The following is a description of a gene set: studied in species Homo sapiens Genes predicted to be targets of miRBase v22 microRNA hsa-miR-6867-5p in miRDB v6.0 with MirTarget v4 prediction scores > 80 (high confidence targets). from publication Chen Y, Wang X (PMID 31504780) Human Gene Set: MIR6867_5P, and this is the list of marker genes: ZSWIM6, KLHL13, NLN, HYKK, PLAG1, CACNA2D2, LDB3, SVBP, CHRDL1, MATCAP1, CSF2RB, ARID3B, BRINP1, RAB3C, EHD2, TNKS, SLC13A5, OPCML, MYLK3, UNC5C, PRKD3, STXBP5L, KCNB1, PPP1R16B, AP1G1, EPS15L1, NLGN4Y, GFPT1, DLG1, BEAN1, TMEM151B, CACNA1I, SSX3, PCDH11Y, FCGR1BP, P2RY8, LRATD1 (LRAT domain containing 1), DCX, RPS3A, TTI1, CHST3, CRHBP (corticotropin releasing hormone binding protein), MAN1C1, PRDM8, PLAA, SIN3A, PLVAP, ZEB1, GPBP1L1, GIMAP1, KCNIP3, CLEC12B, RHOBTB1, ATP8B2, KCNQ3, BDH1, SEMA6A, PARD3B, LMX1B, LEPR, BRWD3, JAKMIP2, PDE10A, ENPP5, RNF113B, MESP2, VAPB, SMAD4, NRXN3, GNG7, ABR, ITIH5, NACC1, CREBBP, IGF1R, PODN, FUT9, TRPV3, ASXL2, ZDHHC20, SLC7A8, MTCL2, TULP3, UBQLN2, PLP1, PHF1, TTC9, EML1, FAM228A, PCDH10, ATP11A, TLK2, TTC1, PTAR1, PKNOX2, SH2D2A, TMEM196, CCDC83, ELAVL4, SIGMAR1, DOP1A, MAP4K5, FAM43A, NAPB, SLC35A3, DELE1, ZFX (NCBI Gene Id 7543), SERTAD2, TFAP2B, ATP6V1C2, ZNF382, SLC6A14, UNK, SDK2, ENSG00000255537, EHD3, NAPEPLD, JMJD8, RPL23A, LDHAL6A, CBX1, PREX2, SNAP25, NFIC, CD38, TANGO2, ANAPC7, RBMXL1 (RBMX like 1), NLK, FIBIN, PPP1R3A, TPTE, IL2RA, ABHD18, ASB7, MALT1, SPATA6, FRMD3, HSPG2, DOK6, PARM1, HLA-DOA, DDHD1, PLEKHA6 (NCBI Gene Id 22874), FNDC7, NDFIP2, EFHC2, FGF2, LCE1E, TAOK1, KDM3B, ASTN1, CLIC6, RALB, ADAM12, KCNQ5, FZD5, TNPO3, KIAA1549L, EFNB1, MDGA1, CREB3L2, CTSE, REEP5, RIGI, ST18, CD40LG, HSPB7, DLG4, LRTM2, KCNK10, GLS, APBA1, PAPSS2, NEXMIF, SSX4B, CD247, GPR173, ERP27, GARRE1, TMEM106A, PRKN, SLC16A14, ADAT2 (adenosine deaminase tRNA specific 2), LAIR1, ELFN1, SH3TC2, NCDN, MECP2, PFN1, DLGAP4, CSRNP3, SLC2A12, CCDC97, TBX15, KLF7, ARHGAP35, SBK1, DDX52, ZNF516, RRP7A, MAF, ZNF704, SATB1, TRIM2, UBN2, NTRK2, ALG1, ZNF148, KRIT1, FOXI2, IGLON5, STBD1, OLFML1, CDON, RBPJL, CSNK1G1, CARNS1, RNF220, MGRN1, CALD1, KPNB1, ZFP90, CHODL, PAX5, TBX4, ZFHX2 (zinc finger homeobox 2, NCBI Gene Id 85446), SPCS2, PIGH, ZNF488, INSIG2, ANTXR2, CDH11, TEAD1, ADCY2 (adenylate cyclase 2), GLP1R, EP300, TLX1, SPOCK2, SLCO4C1, STS, PAX6, NCAPH2, MYO5A, WWC1, BRINP2, SORCS3, RFTN2, SVIP, SPTLC3, GTF2H1, GNAT1, SLC22A23, RSPO1, ZC3H12D, SV2B, SPPL3, SNAP29, CSRNP2, AMER3, ADAM23, ACOD1, GRIN3B, SSX5, MACROH2A2, SSPN, WDR33, RSPRY1, IFNLR1, ARHGEF33, EIF2A, NCAM1, SHISA7, UNC5A, SOX12, ZNF563, LCP1, SLCO3A1, NEK11, CISD3 (NCBI Gene Id 284106), GRIN2A, TRIM42, CDKN2B, CLVS2, GALNT13, KLHL9, ETV6, KIF5A, MORC2, SSX2, RPH3A, NFASC, TENM2, ARHGAP26, KATNAL1, VAMP4, ZNF134, ZFY, IARS1, SGCZ, ATXN3, MGAT4A, IFT80, EBF3, TMEM150C, AMOTL1, NGFR (nerve growth factor receptor), CPPED1, F7, ZNF436, LRRC55, SNAI2, RALGAPB, STRBP, SBSPON, ELOVL6, CALCOCO1, POU4F2, MUC4, GALR2 (NCBI Gene Id 8811), ZKSCAN8, PURA, ADAMTSL1, SH3BGRL2, ATP2B2, CPED1, RET, GFRA2, ZEB2, TEAD3, PIK3C2A, GALNT3, CCDC93, KCNQ2 (potassium voltage-gated channel subfamily Q member 2), SYT3, BCOR, PPARA, KAAG1, SLC1A4, SEMA6D (semaphorin 6D), HAS2, NLGN3, SSX7, MBNL3, CD22, FAM117B, DMD, MYT1L, ANO5, PRKCI, WIZ, PAX4, PIK3R5, VGLL3, PLCB1, ADAMTS19, GDAP1, RSPO4, SOX6, SCN2A, STARD8, GFRA1, CSMD2, GABRB2, STX1B, RNLS, E2F8, TNS1, DGKH, PBRM1, SAMD4A, ZFHX3, AKT3, PALM2AKAP2, SYNPO2, NMBR, BEND6, CREM, LUM, PIAS2, ZNF37A, FAM177A1, VPS13C, ROCK2, NRXN1, SLC31A1, ZMYND8, MFSD6, SEPHS2, SETD7, ADAMTS5, ZNF329, GREB1, TREML2, MXD1, ERO1B, TIAM1, USP37, LHX6, RGS4, CAMK1D, ST8SIA1, DCAKD, CELF5 (NCBI Gene Id 60680), BDNF, KLHL15, CABP4, ZHX3, CLIP2, BMP4, ELFN2, VSTM2A, SMARCA2, FCRL6, ARHGAP42, TNRC6B, COPG2, GABBR2, ASB11, PATE2, ZRANB1 (zinc finger RANBP2-type containing 1), OLR1, ARHGAP45, CDH13, INHBA, GABRG3 (NCBI Gene Id 653227), TRDN, STAT6, UBE2QL1 (ubiquitin conjugating enzyme E2 QL1), NEPRO, AFF2 (NCBI Gene Id 2334), SNX20, EDA2R, CASZ1, ATMIN, SLC25A6, DUSP7, PTCHD1, INVS, TMEM47, SETDB2, VSNL1, TRAF3, ERO1A, RFX3, CSRP2, TACC1, MUC13, MARCHF4, SRD5A3, HS3ST4, CLEC2L, IRF2BPL, HCN4, SLC4A4, GRM5, RNASE1, FLRT2, DNAJC6, ALOX15B, TCP10L, WDR73, YIPF6, AIMP1, HOXC6, TIPRL, VAX1, LRRC39, FASTKD2, EPAS1, PRKCB, HDAC9, ATP1B2, ZNF439, BNC2, BPTF, FAM78B, FAXDC2, SYT17, LRRK1, OPRM1, TP53I11, SHB, CCDC40, NIN, USF3, RIBC1, LPP, FAM13B, ZFP36L1, BIN2, TMCO1, TNFSF14, BCL2, PRR23D1, CYP4F11, ONECUT2, CHIC1, RAB3IP, ZDHHC3 (NCBI Gene Id 57245), PCGF3, SSR1, MBLAC2, ESCO2, SLC6A7, UCK1 (uridine-cytidine kinase 1), EOGT, ANKRD34A, TSTD3, MRO, GREM2, EN2, ZNF850, TVP23A, KIAA1671, SEPTIN3, LAMP2, KANSL1L, DCAF8L1, ARRB1, FAM167A, TMEM241, PATL1, AMER1, LSAMP, RUFY2, CHD7, PLCG1, UFL1, SPX, KCNN3, PLXDC2, ZNF589, MNT, WIPF2, PTHLH, KCNJ16, NUFIP2, SLC35E3, MYD88, APRG1, GNE, AVL9, PSMA4, P2RX1, TBC1D16, CA10, DCN, LRRN1, LIMK1, SYAP1, FSD2, RBBP9, MAP3K2, GRIA3, HTR5A, FAM13A, CDH6, ANK1, VSIG10, NUAK2, SLC48A1, ABCC4, APBB2, TRIM13, FBRSL1, ADCY9, CHST11, IGF2R, IGF1 (insulin like growth factor 1), FAM163A, RASD2, SERTM1, INO80D (NCBI Gene Id 54891), CAPN6, DESI2, ZNF544, MYLK4, BTBD9, KIAA0040, H2AJ, P3H2, SMIM21, IPO9, FUNDC2, GPR83, MAP2, FAT3, SSX4, FBXO47, ATP2B3, XKR4, CPLX3, GRK3, RBM46, CDK15, CACNG2, ILRUN, LCOR, NRK, XG, GNAL, SPIN1, NLGN4X, NDE1, RIMS1, STXBP6, CORO6, SNX2, PBX2, SCRT2, CACNA1A, BVES (NCBI Gene Id 11149), IKZF2, FGFRL1, RAB6D, SPN, NKAIN2, NR2F1, ADRA1A, CHORDC1, SAMD9L, LRRFIP1 (LRR binding FLII interacting protein 1), DPYSL5, LRRTM2, RARA, FOXN3, PLEKHM3, IFFO2, METTL21A, TRAF3IP2, STOX2, AJAP1 (adherens junctions associated protein 1), TXNL4B, CSMD1, PRDM7, PORCN, BMPER, AHNAK2, VNN1, ASH1L, HACD3, CHST2, GFAP, ACTR1B (actin related protein 1B), GRIA4, AFF3, ATF7 (activating transcription factor 7, NCBI Gene Id 11016), HOXB4, GALNT1, SHANK2, PLXNA1, BCL2L11, LARP4B, ZFP91, HTT, PECAM1, SSX1, APOL6, PRDM12 (PR/SET domain 12), ANKRD42, NOX4, NECTIN1, TAF2, FLNC, LYST, SHOC2, LRP2BP, FUBP3, ZNF529, ST6GALNAC5, RTN1, B4GALNT1, GNAZ, MOSMO, CCKBR, PLPPR1, NOS1, A1CF, SPRY4, ADAMTSL5, SIRPA, CAMTA1, CAMKK1, PPP1R1A, PDGFB, LILRB4, HNRNPA0, NCK2, GADL1, TRIOBP, DNAJC15, TMEM130, SH3RF3, PRDM11, RGS3, SYNPO, RCVRN, ZSWIM1, DGKG, PEA15, SRGAP2, LHFPL6, HOXC4, SLC25A43, EGFR, MCM8, GLI2, CALHM5, ANO8 (anoctamin 8), SHISAL1, BMP3, PYGO1, SDC3, SLITRK3, PTPRM, PABIR3, RBFOX1 (NCBI Gene Id 54715), KLHL23, LATS2, SLC7A11, MAPKBP1, CDIN1, GPATCH2L, CD93 (CD93 molecule), FAM163B, NUGGC, ZNF655, PRR18, PDLIM5, TRARG1, PACSIN3, CUX2, MPEG1, CYTH3, ZBTB20, ATP6V1C1, SEMA5B, IRAG1, SGPL1, TDRP, MS4A2 (NCBI Gene Id 3477), GRID1, GJB4, GPRC5B, FLVCR1, GABRB3, CAMK2N1, FOXP3, ARL8B, CCDC191, FSTL4, PTGFR, GLYR1, GNA12, IL6ST, SEMA3E, RORA, FIGN, HPS3, FKBP1B, RBP3, CREBRF, FRMD5, WNT4, EPHA5, MEGF8, CNTN3, KAT6A, SCARA3, SPARC, SEPTIN6, ATP8A2, ZNF101, OXTR, GCN1, SMAD9, ENOX2, TRIM67, SAMD12 (sterile alpha motif domain containing 12), PATE1, HPCA, ITGB1BP1, RGS5, ZDHHC15, DLG2, TSPAN2, ADGRA1, NFAT5, CADM4, SCP2, PIM1, THSD7A, PHF20L1, SLC23A2, RUNX1T1, KLF12 (NCBI Gene Id 82238), THRA, SERPINA10 (serpin family A member 10), SLC44A1, PAG1, SLC24A2, PDLIM2, EHHADH, OSBPL9, ZNF449, BID, HDAC8, RIC8B, NR2E1, NCAN, PITPNB, UGT3A1, LHX1, PDGFD, SIX3, CNTNAP5, JARID2, TMEM237, CAMK4, FOXN1, PBLD, GTDC1 (NCBI Gene Id 79712), UBQLN4, CCDC198, MAGEE2, MCTP2, PPP2R1B, PLCXD3, RAB7A, SSX2B, DOCK1, PCDH11X, GYPA, MAPK10, SRF, HS6ST3, RRP15, SLC5A12, KMT2A, PROX1 (prospero homeobox 1), CELF4, KIF1B, CA8, SENP1, ZNF618, SLC43A3, UBLCP1, NAV1, ALX4 (ALX homeobox 4), NR4A2, ABO, FREM2, CCSER2, CYLC2, DMRTA1, TMPRSS11A, SCN5A, FAM83C, SLC26A6, C1orf94, C1orf21, AAR2, INSYN2A, DLG3, MARCHF3, ZNF264, RICTOR, ATRN, CDH12, LYRM7, NKIRAS2, LHFPL5, IL20RB, SOX7, EFCAB11, SCN8A, TMBIM4 (transmembrane BAX inhibitor motif containing 4), C10orf71, CCND1, ITGAM, RSPH4A, CYP4V2, DUSP16